Given this list of marker genes PPARG, ATP6V1A, ANTXR1, MST1, ALDH18A1, CAV1, PDGFRB, CAVIN1, AEBP1, FOS, SLC39A13, COG4, BSCL2, SLC25A24, PIK3R1, IPO8, POLR3A, LMNA, FLT4, BANF1, ATP6V1E1, PTDSS1, C1S, ATP6V0A2, VEGFC, ZMPSTE24, PYCR1, G6PC3, LEMD2, RASA1, C1R, PPP1R15B, TCF4, SEMA4D, AGPAT2 (NCBI Gene Id 681), GPR35, here is a description of the gene set: species: Homo sapiens Prominent superficial blood vessels Human Gene Set: HP_PROMINENT_SUPERFICIAL_BLOOD_VESSELS